Given this list of marker genes NFIL3, CTDNEP1, C12orf43, SIGIRR, TNFSF8, CDKN2D, NSMCE1, GET4, ARF1, PROS1, RNF126, DUSP12, ZFP91, IL21R, IER5, MAN1A1, EMP1, FUT8, CKS2, NGDN, NUBP2 (NUBP iron-sulfur cluster assembly factor 2, cytosolic), IL2RA (NCBI Gene Id 3559), RBKS, PRKCH (NCBI Gene Id 79030), CHM, PSTPIP1, JRK, CASP6, CYFIP2, ATF1, NDUFB7 (NADH:ubiquinone oxidoreductase subunit B7), ATF6, COA7, MANF, AIG1, GPR65, SDHC, UMOD, SKAP2, PTDSS2, RAB27A, OPRM1, ATG3, EGLN3, LRRC8C, CD200R1, CRYBG1, PTPN1, AHR, SUCLG1, POP7, ARID5B, RNF4, LPXN, RNF121, RAP1GDS1, SOCS3, ID1, UBE2S, OAS2, TRAF3, SSR2, MYDGF, ERG28 (ergosterol biosynthesis 28 homolog), RNH1, FLOT1, MAPKAPK5, PTPN4, CHD7, BATF, RRP36, RORC, GSS, ANKRD46 (NCBI Gene Id 157567), PPP1CC, SLC13A3, IGFBP4, SLFN13, VAV1, ARF6, AFG2A, FPGS, PMEPA1, AOPEP, STK19 (serine/threonine kinase 19), CACNA2D3, CHST2, JAGN1, GFI1, SLC30A4, CIAPIN1, SMAD3 (NCBI Gene Id 51521), PRKCQ, MBOAT1, AUH, TIMP1, ADPRM, PEX11B, PLAC8, CYB561D2 (NCBI Gene Id 11068), DAP3, NUP58, GPR146, NLE1, IL4R, PGS1, SYTL3, PIGM, C19orf25, PRDM1, MRPS24, VMP1 (NCBI Gene Id 81671), TWSG1, SEMA4D, AKT2, DENND4B, ICAM1, RAB20, LPP-AS2, MRPS23, SIRT2, TXNRD1, HIC1, SELP, PKM, PBX2, IRF4, CD28, RBPJ, UBFD1, HOOK2, NCS1, VPS54, PSMD9, NEUROG2, GNPDA1, EMB, CD6, SGPP1, BCL3, KRI1, CEBPB, ANAPC11, TMEM109, JUNB, NOP9, GSR, FMC1, PDIA6, CYB5B, RORA, PHLDA3, UBA1, FRMD4B (NCBI Gene Id 23150, FERM domain containing 4B), PIAS2, SMIM3, INO80B, SATB1, CDC73, STING1, JAK3, CTLA4, RNF19B, SELENOF, JTB, SCAMP3, CRYBG3, KRTCAP2, EXT1, ARMCX3, IGF2BP1, GOLT1B, CHMP4B, JUN, IL4, RCL1, GZMB, TP53I13, PLA2G12A, MED1, CALCRL, NEK6, PTPN2, HK1, GADD45G (growth arrest and DNA damage inducible gamma), SYNGR2, CTSB, SNX10, NDUFB5, AGPAT3, FLT3LG, SSBP4, SEMA7A (NCBI Gene Id 8482), ID2, CTSZ, ATP5MC1, MIDN, ARHGAP39 (NCBI Gene Id 80728), GPX4, ETV6, here is a description of the gene set: Human Gene Set: GSE17186_NAIVE_VS_CD21LOW_TRANSITIONAL_BCELL_UP from publication Suryani S, Fulcher DA, Santner-Nanan B, Nanan R, Wong M, Shaw PJ, Gibson J, Williams A, Tangye SG (PMID 19965666) Genes up-regulated in B lymphocytes: naïve versus transitional CR2 low. Goals/objectives: to identify various gene expression in B cell subsets derived from human PBMC and cord blood species: Homo sapiens